The following is a description of a gene set: studied in species Mus musculus Mouse Gene Set: SRSF1_TARGET_GENES from publication Yevshin I, Sharipov R, Kolmykov S, Kondrakhin Y, Kolpakov F (PMID 30445619) Genes containing one or more binding sites for (Srsf1) in their promoter regions (TSS -1000,+100 bp) as identified by GTRD version 20.06 ChIP-seq harmonization., and this is the list of marker genes: Gm37450, Rab29, Cox7c, Ppib, Rubcn, Gm9245, Dnajb5, Lman1, Yjefn3, Klf7, Ubn1 (ubinuclein 1), Abcg2, Gm24044, Acot8 (NCBI Gene Id 170789), Bcs1l, Sfi1, Gm21092, Gucy1a2, Pigw, Ttll4, Nanp, Ptpa, D030018L15Rik, Tssc4, Brd2, Mthfd2l, Ccnd3, Slfn9, Gm6420, Coq8a, Rlig1, Dynlt1b, Ralgapa2, Homer1, Cercam, Gm17430, Coa3, Gm5447, Ube2v2, Fbxw17, Mmp2, Acbd3, Topbp1, Zfp882, Skap1, Glb1, Rnf227, Myo9b, Noxo1, Rdm1, Spcs1, Snord59a, mt-Rnr2, Sec61a1, Actn1, Dhx40, Pde3b, Wdr45b, Gart, Nktr, Gpx1, Airim, Parg, Ptprv (protein tyrosine phosphatase receptor type V), Gm16740, Gm6445, Ccdc47, Gm13146, Dnah8, Coq9 (NCBI Gene Id 97451), Top1 (topoisomerase (DNA) I), Nbr1, H2-T13, A530040E14Rik, Slc25a28, Gramd2b, 6820431F20Rik, Pgam5 (phosphoglycerate mutase family member 5), Uspl1, Itgb3bp, Phlpp2, Nbn, Cad, Gm13530, Tmem178, Ciart, Zfp142, Zfp82, Itgb1bp1, Snord43, Tagln3, Cops5, Nuf2, Uhrf2, Dusp18, Nme7, Iqcc, Trmt11, Gtf2h3, Atp13a3, Dpcd, Atat1, Cysrt1 (cysteine rich tail 1), Atp5mc1, Cep162, Pcdhb13, Smc1b, Pcyox1l, Znfx1, Cntd1, G530011O06Rikx (NCBI Gene Id 654820), Add1, Rbm4b, Mir6236, Gm16551, 4930547M16Rik, Mid1, Xkr6, Cdkl3, mt-Th, Mettl17, Tab3, Usp35 (NCBI Gene Id 381901), Ccdc88a, Ace, Ufc1, Cdr2l, Mir301b, Dynlrb2, Mtf1, Shpk, Nop56, Sp3, Gm10222, Gm13238, Dars2, Tuba1a, Thoc1, Extl3, Psmd2, Kif3a, H4c8 (NCBI Gene Id 69386), Dph7, Dusp1, Txndc17, Gorab, Rbbp6, H2ax, Cnnm2, Ccn2, Cep104, Zfp36l1-ps, Gm17813, Sox17, Specc1, Tasp1, Trdmt1, Rogdi, Gabpb2, Cilp2, Cul3, Snhg3, Zfp668, Taf1d, Ippk, Crtc2, Jdp2, Ccdc97, Hmgb1, Inpp5k, Septin11, Plin5, Zfp518a, Pbx4, Inhca, Gm5067, Lin7c, Ccdc62, Stt3a, Mir7036b, Vcpkmt, Tra2b, Kdm2a, Snord14a, Gm13135, B130034C11Rik, Mrpl1, Ttc14, Ube2v1 (NCBI Gene Id 66589), Eif2b1, Zfp989, Pter, Mipol1, Asnsd1, Mrps21, Nabp1, Wnt2, Mbtps1, Itga6, Thap1, Ssh1, Gm25697, Snord110, Gm22711, Ergic2, Prpf8, Sowahb, Rpl21, Bcl2l1, Tbc1d32, Gm25878, Psmc5 (protease (prosome, macropain) 26S subunit, ATPase 5), Zmym6, Zfp354c, Ppp2r5a, Gm26901, Hyou1, Gm15247, Btbd9, Ftsj3, Kat7, mt-Tv, Nyap1, Zfp646 (NCBI Gene Id 233905), Dcaf6, Lrrk1, Rpn2, Zfp1, Stat2 (NCBI Gene Id 80602), Ppp4r3a, Rbm14, Ttll6, Gm11335, Gm15545, Man2c1, Mir8092, Snora73a, Secisbp2, Son, mt-Tl1, Gm13384, Prdx1, Gm26787 (NCBI Gene Id 102637672), Plgrkt, Ccnb1ip1, H2ac19, 4931406C07Rik, Yipf2 (NCBI Gene Id 74766), Gm6483, Man2c1os, Zfp963, Cdca8, Fcgr2b, Snord2, Eif5, Wfs1, Paip1, Trrap, 4933427D14Rik, Rffl, H4c4, Rgs2, Ighv1-67, Pisd, Rap1gds1, Gm23301, Mtg2, Kpna4, Gstp1, Lzic, 6530401F13Rik (NCBI Gene Id 76241), Adprs, Gla, Tnfrsf22, H60b, Zswim3, Dgcr2, Sox5, Arl6ip4, Ankrd42, Raet1e, Rcc1, Tars2, Gm11520, Osgin2, Synj1, Cspp1, A430108G06Rik, Gtf2h2, Vcpip1, H2ac21, Zc3h10, Phf14, Gjd2, 1700034P13Rik, H2-Q10, Ctnna3, Gm10941, B4gat1, mt-Nd5, Mir7655 (microRNA 7655), Jpt2, Ttc39d, Gm26744, Eef1a1, Hace1, Rbm38, Atpaf1, Cenpl, Zfp563, Tubb6, Ercc6l2, Krit1, Gm8357, H2-Q7, Pphln1, Gpi1, Bicd1, Matr3, A530072M11Rik, Zfp992, Pdik1l, Ifnar1, Gm3242, Ighv8-5, Ndufa10, Ppara, Sdc4, Ephb3, Rpl3, Akap7, Teddm2, 4930429F24Rik, Iscu, Gmcl1, Endod1, Mroh8, Zfas1, Mbtd1, Rab14, Fbxo22, Utp3, Uimc1, Rars1, Zfp599, Gm11400, Ddx42, Glp1r, Gm21411, Ttyh2, Plch1, 4921536K21Rik, Wars2 (tryptophanyl tRNA synthetase 2 (mitochondrial)), Btbd19, Filip1l, Esco1, Hspa4, Gon7, Tctn3, Ak6, Akap9, Mllt3, Med1, Calm1, Mm2pr, Ripor2, Tubgcp6, 1700028B04Rik, Timm23, Mccc2 (methylcrotonoyl-Coenzyme A carboxylase 2 (beta)), Ctdspl2, Id4, Igf2bp1, Tmbim6, Hectd2, Sde2, Ankib1, Gm13162, Snord104, Crmp1, Rpsa, Rad17, Tsg101, Cxcl3, 1700125G22Rik, Abraxas1, Duxf1, Psip1, Zfp990, Oasl1, Foxk1, Hspe1, Gm21978, Eci1, Fancl, Akap10 (A kinase anchor protein 10), Shb, Snx14, Rps6ka5, mt-Ts2, Eif4a2, Dnttip2, Tipin, Hspa5, Bin2, Mettl5, Blzf1, Zfp952, Asah1, Ankle2, Dnah6, Mapk6, BC002059, Ttll7, Jak1, Wiz (NCBI Gene Id 22404), Ifnz, 4930597O21Rik, Zfp640, Zfp988 (zinc finger protein 988), 4933406I18Rik, 2210409E12Rik, Tfrc, Gm5577, C030034I22Rik, BC023719, Gm13141, Parpbp, Upf3a, Nadsyn1, Utp18, Tube1, Smg5, Gsto2, Epha7, Mob3c, Mgat5b, Galk2, Gm8815, Irgm1, Psme4, Cldn7, Sf3b1, Mettl5os, Rpl10a, Mylpf, Atf5, Gpx4, Rps13, Zfp638, Ctns, Cdiptos, Ankrd2, Gm26504, Ninl, Phrf1, Zfp133-ps, Gng12, Ccdc102a, Eif5a, Fubp1, Qser1, mt-Tl2, Ppard, Atp6v1h, Snapc5, Mdfic, Duxf4, Gm16794, Ndufa4, Mrpl39, Cdk17, Adnp (activity-dependent neuroprotective protein), Polr1b, Gm10642, Ppp4r3b, Vmn2r-ps19, Pld2, Ubc, Cpsf2, Spr, Tor1b, B3galt4, Canx, Ppp4r2, Fryl, Vmn2r-ps20, Gm13239, Cct8, 2610005L07Rik, Gm22973, Agbl5, Eif4a1, Ciapin1, Atp5f1a, Ank1, Pate2, Ighv1-32, Srsf7, Uqcrc1, Gm16638, H1f4, Pik3c3, Fam229b, Zscan12, Gm15564, Mettl25b, Fam220a, Rock1, Ndufc2, Tdrp, Trmo, Uggt1, Exoc2, Dctn6, Dhcr7, Sgo1, Psmd3, Lrrc28, Ssbp3, Trpv2 (NCBI Gene Id 22368), Clcc1, mt-Nd1, Sumf2, Itch, Sergef, Taf12, Kcnj4, Snord58b, Llgl2, Pex1, Cep164, Gm10420, Timm9, Glul, mt-Tp, Glyr1, Shfl, Mrpl21, Brca1, Egf, Crat, Rpl37a, 5930411N13Rik, Fignl1, Dcaf15, Zfp825, Rcn2, Nmnat1, Tspoap1 (TSPO associated protein 1), Helz, Zfp322a, Ndufb6, Sart3, Grb2, Pikfyve, Mir130b, Glt8d1, Ribc2, Pik3c2a, AU041133, Rps5, Gm13034, Adam10 (a disintegrin and metallopeptidase domain 10), Nr1h2, Pik3ca, Thada, Ighmbp2, Rnd2, Taf9, Purb, Rbm25, Il4i1, Sdf4, Dok4, Stard5 (NCBI Gene Id 67714), Sub1, Raf1, Pdcl, Etv3, Ywhae, C920021L13Rik, 1700008O03Rik, Atp5f1b, Cd276, Mtx2, Mmab, Tmppe, Ash2l, Ighv1-64, Zfp998 (zinc finger protein 998), Gm21992, Vkorc1